Given this list of marker genes ERCC2, POLR2D, NELFE, GTF2F2, POLR2B, GTF2H4, GTF2H3, POLR2L, ELOA2, CDK9, SUPT4H1, POLR2C, GTF2H2, NCBP2, POLR2K, NELFCD, TCEA1, ERCC3, GTF2H1, CCNT1, CTDP1, POLR2A, ELL, NELFA, POLR2I, NCBP1, POLR2J, GTF2H5, SSRP1, GTF2F1, POLR2E, ELOC, MNAT1, POLR2F, ELOA, SUPT5H, CCNH, POLR2H, SUPT16H, POLR2G, ELOB, CDK7, tat, NELFB, here is a description of the gene set: part of: Tat-mediated elongation of the HIV-1 transcript Reactome Pathway: Formation of HIV-1 elongation complex containing HIV-1 Tat studied in species Homo sapiens The details relevant to HIV-1 are described below. For a more detailed description of the general mechanism, see the link to the corresponding RNA Pol II transcription event below. The formation of the HIV-1 elongation complex involves Tat mediated recruitment of P-TEFb(Cyclin T1:Cdk9) to the TAR sequence and P-TEFb(Cyclin T1:Cdk9) mediated phosphorylation of the RNA Pol II CTD as well as the negative transcriptional elongation factors DSIF and NELF.